The following is a description of a gene set: Mouse Gene Set: GOBP_REGULATION_OF_NITRIC_OXIDE_METABOLIC_PROCESS species: Mus musculus Any process that modulates the frequency, rate or extent of the chemical reactions and pathways involving nitric oxide, nitrogen monoxide (NO), a colorless gas only slightly soluble in water., and this is the list of marker genes: Icam1, Epor, Jak2, Rock2 (Rho-associated coiled-coil containing protein kinase 2), Gimap3, Gimap5, Smpd3, Acp5, Tnf (tumor necrosis factor), Hrh1, Mapk9 (NCBI Gene Id 26420), Ptx3, Clu, Il4, Ptgis, Sirpa, Clec7a, Itgb2l, Dnm2 (dynamin 2), Npy, Il6, Klf2, Cx3cr1, Ulbp1, Akt1, Dynll1, Agxt2, Il1b, Tlr5, Selenos, Hsp90ab1, Klrk1, Gla, Khsrp, Ticam1, Il10, Ptk2b, Cd36, Raet1d, Tlr4, Trpv1, Rgn, Cav1, Akt2, Nosip, App, Hsp90aa1, Cd47, Nfatc3, Wdr35, Klf4, Pik3cb, Zc3h12a, Itgb2, Sod2, Tspo, Smad3, Ptgs2, Ifng, Atp2b4, Insr, Igf1 (NCBI Gene Id 320499), Oprm1, Acvr2a, H2-M3, Asl, Tmem106a, Crp, Apoe (NCBI Gene Id 11816), Ddah1, Esr1, Mtor, Ass1, Rac1, Tlr6, Tlr2, Aif1, Agt, Pkd2